Given this list of marker genes MARCHF5, PCNT, STK17B, FUT9, CST9L (cystatin 9 like), CPA4, UBC, LMX1B, DUSP4, NRIP1, FYB1, SRXN1, KIF1A, DSCAM, CC2D2B, GPR132, ZC3HC1, PLA2G4F, GNL3, MMS22L, RAVER1, RCL1, ARG2, CSE1L, TGM2 (transglutaminase 2), AOX1, SUCO, HSD17B7 (NCBI Gene Id 63064), HELZ2, TBX3, TNIP1, DNAJC8, PBX1, TENT4A, ZNF703, HHAT, ARL6IP1, WASF1, IMP4, TUBGCP3, MCEMP1, RCHY1 (ring finger and CHY zinc finger domain containing 1), RALGDS, SMIM3, NRG4 (neuregulin 4), EFEMP1, CDIN1, TSPY1, SLC43A3, ERCC6, AP3B1, TSPAN33, GRWD1, VCAM1, ERN2, CLEC5A, NPM3, GRIK4, ARID5A, CCL4, PIWIL2, KAT14, PDGFRA, EHD1, MGAT4A, DYNC1I2, SMIM23, DHRSX, RBM39, IKBKG, FRMD6, DYNLT4, CYP2W1, RAB3GAP2, ZNF558, MEST, PHLDA2, MSR1, POF1B, CXCL6, GADD45A, ORC6, SRF, JAK2, CSF3R, AHSG, SLC30A6, VTI1B, MMUT (NCBI Gene Id 4594), C9orf72, OSGIN2, PSAP, HEXIM1, INPP5E, CASP4, LY6G6C, ADAP2, SRA1, KCNJ9, MDM2, PLA2G5, SYT16, RNASE6, DYRK1A, MINDY1, FBXO17, YJU2, RELB (RELB proto-oncogene, NF-kB subunit), FGF3, KCNS2, NEDD4L, GART, DRC1, STXBP5L, CDHR4, MAP3K8, ATOH8, DAB2, TKTL1, CA1, SMG8, PLEKHH2 (NCBI Gene Id 130271), ABL2, ABCA5, MID1, DGLUCY, VGF, AIF1, RNF103, NIF3L1, MTMR10, KRT84, SUPT3H, FAM167A, PMS2, ARIH2, SFTPA1, OR2S2 (olfactory receptor family 2 subfamily S member 2), SLPI, GOLGA5, PHLDA1, SERPINB9, ZFP36L1 (NCBI Gene Id 677), RTP4, ERRFI1, CR1L, LRRC23, LCLAT1 (NCBI Gene Id 253558), TRMT12, PODXL2, MX2, RNF19B, TTLL8, GPER1, NISCH, CUL3, HSPBAP1, SLFN12L, GALM, TIAM1 (NCBI Gene Id 7074), BAIAP2L1, SNORD89, MAFF, TSSK4, PIH1D2, MCM8, HMGB2, SRRM1, MINDY3, ST3GAL5, NCDN, ITGA8, JUN, CH25H, KIAA1671-AS1, PPP1R10, HESX1, GADD45B, BAG3 (BAG cochaperone 3), CORO1A, FUS, RFX5, ZNF292, ZC3H15, MTMR14 (NCBI Gene Id 64419), DLX6, DLX4, SBDS, HBB, GAS1, ACOT9, HRH4, PARP14, BMAL1, CFAP47, CC2D2A (NCBI Gene Id 57545), C17orf50, MYO9A, TPSG1, MAPK15, here is a description of the gene set: Genes down-regulated in comparison of untreated macrophages at 4 h versus those treated with LPS (TLR4 agonist) at 1 h. Human Gene Set: GSE9037_CTRL_VS_LPS_1H_STIM_BMDM_DN studied in species Homo sapiens IRAK-4 is an essential component of the signal transduction complex downstream of the IL-1- and Toll-like receptors. Though regarded as the first kinase in the signaling cascade, the role of IRAK-4 kinase activity versus its scaffold function is still controversial. In order to investigate the role of IRAK-4 kinase function in vivo, ‘knock-in’ mice were generated by replacing the wild type IRAK-4 gene with a mutant gene encoding kinase deficient IRAK-4 protein (IRAK-4 KD). Analysis of bone marrow macrophages obtained from WT and IRAK-4 KD mice with a number of experimental techniques demonstrated that the IRAK-4 KD cells greatly lack responsiveness to stimulation with the Toll-like receptor 4 (TLR4) agonist LPS. One of the techniques used, microarray analysis, identified IRAK-4 kinase-dependent LPS response genes and revealed that the induction of LPS-responsive mRNAs was largely ablated in IRAK-4 KD cells. In summary, our results suggest that IRAK-4 kinase activity plays a critical role in TLR4-mediated induction of inflammatory responses. from publication Koziczak-Holbro M, Glück A, Tschopp C, Mathison JC, Gram H (PMID 18266302)